Given this list of marker genes Hes1, Nr2e1, Ascl1, Hes3, Sox5, here is a description of the gene set: Mouse Gene Set: GOBP_REGULATION_OF_TIMING_OF_NEURON_DIFFERENTIATION The process controlling the activation and/or rate at which a relatively unspecialized cell acquires features of a neuron. species: Mus musculus